The following is a description of a gene set: species: Mus musculus The process pertaining to the initial formation of the mammary gland from unspecified parts. The process begins with formation of the mammary line and ends when the solid mammary bud invades the primary mammary mesenchyme. Mouse Gene Set: GOBP_MAMMARY_GLAND_FORMATION, and this is the list of marker genes: Tbx3, Pax3, Gli3, Tbx2, Lrp6, Fgfr2, Nrg3, Bmp4, Fgf10 (NCBI Gene Id 14165)